The following is a description of a gene set: Genes predicted to be targets of miRBase v22 microRNA hsa-miR-34c-3p in miRDB v6.0 with MirTarget v4 prediction scores > 80 (high confidence targets). from publication Chen Y, Wang X (PMID 31504780) Human Gene Set: MIR34C_3P studied in species Homo sapiens, and this is the list of marker genes: MAP3K2, NIPAL2, NHEJ1, MBD5, LYST, MRPL42, CAPZA1, CWC15, MAGI3, EIF4E, BICC1, PRKAR2B, APC, SIKE1, FLT3, PPP6R3, DCBLD2, RNF128, TAF1B, ZDHHC21, SP100, CAPRIN1, SLC2A13, KCNMB3, FCHO2, EIF4E3, AEBP2, DHX9, SMIM10 (NCBI Gene Id 649943), NCKAP1, SVIP, KATNAL1, SMAD2, MTMR6, OTUD3, GPATCH8, SPATA22, TCAIM, RTL9, MARK1, C3orf52, WDR76, CFL2, DNAAF6, TMOD1, SCAI (NCBI Gene Id 286205), SYPL1, CAPN1, PPP3CB, TNPO1, PRSS23, SETD3, RANBP9, KIF3A, P2RY4, DNAJC16, SLC9A6, PLEKHA1, HYCC1, HAUS2, DMRTA1, GGPS1, PDX1, UGT2A3, TIPARP